The following is a description of a gene set: Human Gene Set: GOBP_AMINO_SUGAR_CATABOLIC_PROCESS studied in species Homo sapiens The chemical reactions and pathways resulting in the breakdown of any amino sugar, sugars containing an amino group in place of a hydroxyl group., and this is the list of marker genes: GNPDA1, AMDHD2 (NCBI Gene Id 51005), CHI3L2, NPL, CTBS, CHIA, MGAT1, CHI3L1, OVGP1, NAGK, CHIT1, GNPDA2, ALDH1A1, RENBP